Given this list of marker genes BAD, KIT, PIK3CA, PIK3CD, AKT3, PIK3CB, AKT2, AKT1, here is a description of the gene set: Human Gene Set: KEGG_MEDICUS_VARIANT_MUTATION_ACTIVATED_KIT_TO_PI3K_SIGNALING_PATHWAY Pathway Definition from KEGG: KIT* -> PI3K -> PIP3 -> AKT -| BAD Mutation-activated KIT to PI3K signaling pathway. Pathway ID: N00046. Pathway type: Variant. Pathway class: nt06275 Acute myeloid leukemia. studied in species Homo sapiens